Given this list of marker genes Drd1, Dlx2, Arx, Fezf2, Rac1, Cntn2, Drd2, Ascl1, Dlx1, Lhx6, Nkx2-1, Rac3, here is a description of the gene set: studied in species Mus musculus Mouse Gene Set: GOBP_CEREBRAL_CORTEX_GABAERGIC_INTERNEURON_DIFFERENTIATION The process in which a relatively unspecialized cell acquires specialized features of a GABAergic interneuron residing in the cerebral cortex.